The following is a description of a gene set: species: Mus musculus Mouse Gene Set: GOBP_REGULATION_OF_TRIGLYCERIDE_METABOLIC_PROCESS Any process that modulates the frequency, rate or extent of the chemical reactions and pathways involving triglyceride, any triester of glycerol., and this is the list of marker genes: Fgf21, Esr1, Nr1h2, Thrb, Pik3cg, Mfsd2a, Ccnc, Gpam, Scarb1, Serpina12, Nr1h3, Slc27a1, Dgat2, Abhd5, Mboat7, Tbl1xr1, Sorl1, Plin5, Lmf1, Apoc2, Apobec1, Apoh, Apoc2l, Pank2, Tmx1, Sik1, Gpld1 (NCBI Gene Id 77224), Rgn, Nr1h4, Acsl5, Srebf1, Tcf7l2 (NCBI Gene Id 21416), Cideb, Sirt1, Thrsp, Apoa5, Ces1g, Gnb3, Aadac, Ctdnep1, Daglb, Kat5, Apoc3, Atg14, Cdk8, Apoa4, Pnpla2, Apoe, Ldlr, Cidec, C3, Dgat1, Cnep1r1